Given this list of marker genes PRM1, BRDT, H1-7, H2BC1, SELENOF, CHD5, EPC1, SRPK1, TNP1, SYCP1, SYCP3, TSSK6, PIWIL1, TNP2, RNF8, FSHR, CCER1, PSME4, KAT5, here is a description of the gene set: The progressive compaction of the spermatid chromatin so that it reaches a level of condensation that is not compatible with nuclear activities such as transcription or DNA replication. Human Gene Set: GOBP_SPERM_DNA_CONDENSATION species: Homo sapiens